The following is a description of a gene set: studied in species Homo sapiens Inflammation of the peritoneum. Human Gene Set: HP_PERITONITIS Peritonitis, and this is the list of marker genes: NUP37, COL4A3, BRCA1, PAX2 (paired box 2), NUP85, JAK2, ARHGAP24, MEFV, EMP2, NCF2, MYO1E, NUP107, NUP93, TBC1D8B, NUP160, INF2, NPHS1, NUP133, ARHGDIA, CFB, MAGI2 (membrane associated guanylate kinase, WW and PDZ domain containing 2), COQ8B, CD2AP, CDC45, TRPC6, APOL1 (apolipoprotein L1), ACTN4, F5, NPHS2, MVK, CALR, FOCAD, ANKFY1, TNFRSF1A, GAPVD1, ELANE, DAAM2, PLCE1, CRB2 (crumbs cell polarity complex component 2), MYH11, ANLN, WT1, PTPRO, NUP205